Given this list of marker genes Ifi207, Tbcb, Tubb2b, Lgals9, Irgm1, Slfn5, Cybb, Ifi204, H2-T22, Psme2, Apod, Phf11b (NCBI Gene Id 236451), Ms4a4c, Ifi27l2a, Bst2, Usp18, Parp14, Trim30d, Tmsb10, Smim5, Carmil1, Bbx, Ifitm3, Gng12, H2-K1, Ntrk1, Ldlr, Tspo, Zbp1, Taldo1, Ctsl (NCBI Gene Id 320361), Trim30a, Dynll1, Klk1, Tapbp, Ptms, Dnaja1, Pmepa1, H2-Q7, Sp110, Ddx60, Svbp, Rnf213, S100a6, Anxa7, Epsti1, Samd9l, Hsh2d, Ccnd1, Tuba1a, Lrp8, B2m, Sp100, Ms4a6c, Eif2ak2, Sdc3, Ifi44, Dnajc7, Phf11a, Sct (secretin), Shisa5, Ly6a, Tuba1b, Calm1 (calmodulin 1), Ly6c2 (NCBI Gene Id 100093633), Parp9, Stat1, Rell1, Pttg1, Mpeg1, Sdc4, Ifi213, Cnn2, Hspa8, Pml, Oasl2, Irf7, Tor1aip1, Isg20, Rnase6, Asb13, Ifih1, Nmi, Trafd1, Sat1, Hck, Jaml, Ifi203, Ube2l6, Gbp2, Xbp1, Lgals3bp, Actg1, Spib, Atp1b3, Plac8, Nlrc5, Slc25a22, Iigp1, H2-D1, Selenow, Sh3bp2, Sgcb, Tmbim6, Tagln2, Kdr, Cd82, Casp4, Dhx58, Atp6v1d, Usp25, Dbnl, Slfn2, Zfyve1, Xaf1, Ifi35, Prkcd, Rsad2, H2-T23, Reep3, Grn, Pgap2 (post-GPI attachment to proteins 2), Rasa4, Hspa5, Stat2, Idi1, Samhd1, Ifi209, Tmem219, Cdk14, Pkib, Ifit2, Rap1a, Isg15, Mndal, Ifi211, Acadl, Phf11d, here is a description of the gene set: Genes positively differentially expressed in cell type: pDC (plasmacytoid dendritic cell) upon treatment with cytokine: IFN-κ in mouse lymph nodes in vivo. Mouse Gene Set: CUI_PDC_IFNK_RESPONSE_UP from publication Cui A, Huang T, Li S, Ma A, Pérez JL, Sander C, Keskin DB, Wu CJ, Fraenkel E, Hacohen N (PMID 38057668) Cytokines mediate cell-cell communication in the immune system and represent important therapeutic targets. A myriad of studies have highlighted their central role in immune function, yet we lack a global view of the cellular responses of each immune cell type to each cytokine. To address this gap, the authors created the Immune Dictionary, a compendium of single-cell transcriptomic profiles of more than 17 immune cell types in response to each of 86 cytokines (>1,400 cytokine-cell type combinations) in mouse lymph nodes in vivo. A cytokine-centric view of the dictionary revealed that most cytokines induce highly cell-type-specific responses. For example, the inflammatory cytokine interleukin-1β induces distinct gene programmes in almost every cell type. A cell-type-centric view of the dictionary identified more than 66 cytokine-driven cellular polarization states across immune cell types, including previously uncharacterized states such as an interleukin-18-induced polyfunctional natural killer cell state. species: Mus musculus